Given this list of marker genes ACTG2, MAP2K1, PPP1R1A, ADCY8, GRIA1, RAP1A, MAP2K2, ADCY1, PRKCA, GRIA3, ACTG1, DRD1, GNAS, GRIA4, PRKCB, CALM1, GRIA2, PRKCG, MAPK3, DRD4 (dopamine receptor D4), GRM1, CREB1, PPP1CB, MAPK1, PPP1CA, CAMK4, GRM5, CAMK2A, ARAF, PRKACG, RAF1, PPP1CC, PRKACA, RAP1B, PRKACB (NCBI Gene Id 5567), GRIN1, GNAI1, DRD2, GJB1, ACTB, GRIN2A, here is a description of the gene set: Human Gene Set: WP_COMMON_PATHWAYS_UNDERLYING_DRUG_ADDICTION Common pathways underlying drug addiction studied in species Homo sapiens